Given this list of marker genes RPL11, RPL35, MLH1, RPS10, RPS24, RPS19, RPL31, TSR2, RPS7, GATA1, RPS27, BMPR1A, RPL9, RPS29, ADA2, MAD1L1, RPL35A, RPS26, RPL27, RPL8, GREM1, AAGAB, COL14A1, POLD1, POLE, RPL18, HEATR3, RPS20, MUTYH, RPS15A, RPL5, RPL15, RPL26, RPS28, RPS17, here is a description of the gene set: studied in species Homo sapiens Human Gene Set: HP_ADENOCARCINOMA_OF_THE_COLON Adenocarcinoma of the colon